Given this list of marker genes CLDN20, ACVRL1, PKP2, CDH24, CDH20, CLDN5, VCL, GNPAT, NPHP4, CLDN22, APC, IL17A, DSG1 (desmoglein 1), FLCN, APLNR, PRKCH, SNAI1, WNT11, EPHB2, CDH1, TLN2, MIR142, CDH11, TNF, CDH3, CLDN4, RHOC, CDH9, CLDN3 (claudin 3), MYO1C, PDCD6IP, PECAM1, GPBAR1, CDH6, HIPK1, PKN2, PTPRO, CDH18, ZNF703, LIM2, CDH5, TBX5, F11R, CLDN1, CLDN14, CDH10, CTNNB1, ROCK1, FKRP, SMAD7 (NCBI Gene Id 4092), MPP7, CD9, MPDZ, TRPV4, FBF1, CDH2, STRN, TJP1, GJD3, PRKCA, PKP4, DSG3, CLDN16, IL1B, EPHA2, CNTNAP1, DLG1, CDH17, IKBKB, ANK2, SNAI2, RAC1, UGT8, MARVELD3, RAB13, PARD3, PIP5K1C, AFDN, RPS6, JUP, GJC1, CLDN8, NPHS1, CDH12, CLDN6, OCEL1, POF1B, MIR105-1, PKP3, CDH8, LSR, PRKACA, CLDN2, RAMP2, MICALL2, DLG5, HOPX, CDH4, CNTNAP2, RHOA, CTNNA1, HDAC7, ACE, OCLN, ABI2, CLDN17, GJA1, IRX3 (iroquois homeobox 3), GJA4, CDH7, CDH13, ACTB, ACE2, AGT, CLDN10, ILDR1, GRHL2, CLDN24, PKP1, SLC39A9, CDH15, ECT2, CLDN7, CLDN11, TLN1, CLDN23, CLDN19, CAV1, FSCN1, ESAM, GJB1, GDF2, CDH22, NPHP1, CLDN15, FRMPD2, EPB41L3 (NCBI Gene Id 8730), AMOT, CLDN12, ACTG1, CLDN34, CLDN25, CDH19, GJA5, FZD5, PATJ, GJB6, CLDN9, PARD6B, CDH26, SRF, CDHR3, WDR1, ROCK2, NR1H4, TBCD, ARL2, FER, PAK2, JAM3, GJB2, MARVELD2, CLDN18, here is a description of the gene set: Human Gene Set: GOBP_CELL_CELL_JUNCTION_ASSEMBLY The aggregation, arrangement and bonding together of a set of components to form a junction between cells. studied in species Homo sapiens